Given this list of marker genes PMEL, OPN3, ASIP, APPL1, ATP7A, ZEB2, GIPC1, TYRP1, RAB38, CDH3, here is a description of the gene set: species: Homo sapiens Human Gene Set: GOBP_POSITIVE_REGULATION_OF_SECONDARY_METABOLITE_BIOSYNTHETIC_PROCESS Any process that activates or increases the frequency, rate or extent of secondary metabolite biosynthetic process.